Given this list of marker genes Ret, Sgk1, Nucb2, Got1, Grk2, Bcar1, Irs4, Ptpra, Trib3, Ntrk2, Rps6kb2, Irs2, Snx5, Mir494, Gsk3b, Prkcq, Flt3, Ephb3, Ephb1, Pdgfrb, Mtor, Cdk2, Pid1, Pck1, Mtcl2, Socs3, Pik3r1, Mst1r, Erbb4 (erb-b2 receptor tyrosine kinase 4), Rbx1, Mzb1, Marcks, Agt, Eef2k, Sos2, Eif4ebp1, Gpr21, Sirt1, Ywhag, Sgcb, Tek (NCBI Gene Id 99999), Gpld1, Prkca, Hdac9, Mapk1, Gck (glucokinase), Ptpn1, Ncoa2, Il1b, Obp2a, Rps6kb1, Igf1r, Usf1, Gclc, Ffar3, Slc27a4, Socs7, Prkci, Map2k1, Rb1, Ankrd26, Fut7, Blvrb, Slc2a8, Cul7, Ins1, Ucp2, Pik3ca, Grb7, Hmga1, Stxbp4, Ptpre, Ghsr, Ddr1, Fbp1, Vamp2, Lpin2, Cpeb2, Kbtbd2, Rab8a, Kank1, Gpt, Pten, Ptpn2, Epha8, Cul3, Pdk4, Lep, Pkm, Cav2, Epha2, Ptpn11, Mup2, Ptprv, Foxo1, Sh2b2, C2cd5, Mir143, Flt1, Foxc2, Ptprf, Sorl1, Esrra, Slc2a4, Lpl, Igfbp1, Prkcd, Ptprj, Nucks1, Serpina12, Cpeb1, Appl2, Eprs1, Smarcc1, Axl, Inppl1, Pdpk1, Csf1r (NCBI Gene Id 12978), Srebf1, Sik2, Star, Slc25a33, Pip4k2a, Ncl, Bcar3, Epha5, Xbp1, Zfp36l1, Mfn2, Fgfr2, Blvra, Ndel1, Ide (NCBI Gene Id 73765), Inpp5k, Otop1, Grb14, Pck2, Slc27a1, Slc9a1 (NCBI Gene Id 20544), Ccl2, Lonp1, Epha6 (Eph receptor A6), Ncoa5, Igf2, Atp2b1, Mapk3, Mup1, Epha10, Rab10, Gh, Cyfip1, Uso1, Vwa2, Zfp592, Foxo4, Pdgfra, Ceacam1, Ctsd (cathepsin D), Opa1, Capn10, Uchl3, Grb2, Epha1, Sco1, Dnai1, Osbpl8, Fgfr3, Erfe, Mapkap1, Gstp1, Akt3, Myo1c, Dennd4c, Irs3, Lpin3, Met, Pou4f2, Pik3r2, Egfr, Hras, Mup4, Tsc2, Ceacam2, Pdk2, Tns2, Zbtb7b, Enpp1, Rhoq (NCBI Gene Id 80836), Slc39a14, Epha7, Ntrk3, Zdhhc7, Nr1h4, Rab31, Gpam (NCBI Gene Id 14732), Kat2b, Fbxw8, Rarres2, Pak1, Musk, Tyro3, Ntrk1, Kdr, Ephb2, Ggcx, Fgfr4, Ahsg, Gsk3a, Tnf, Flt4, Tie1, Ncoa1, Ros1, Zfp106, Irs1, Pde3b, Insr, Hnrnpk, Eif4ebp2, Rab13, Insrr, Lpin1, Akt2, Pcsk9, Insig1, Pparg, Mup5, Prkcz, Csrp3, Mup3, Plcb1, Trim72, Erbb2, Rbm4, Sp1, Inhbb, Srsf3, Gnai2, Parp1, Mertk, Sesn3, Ddr2, Ephb4, Ltk, Mstn, Insig2, Gkap1, Src, Col6a1, Ror2, Adipor1, Prkdc, Hmgcs2, C1qtnf9, Nck1, Adipoq, Alk, Apc, Ghrhr, Pik3r3, H2az1, Pax6, Epha4, C1qtnf12, Epha3, Sorbs1, Prkaa1, Akt1, Bglap, Grb10, Shc1, Bglap3, Kit, Sos1, Tbc1d4, Bglap2, Ins2, Fer, Trarg1 (trafficking regulator of GLUT4 (SLC2A4) 1), Syap1, Pip4k2b, Mup11, Wdtc1, Appl1, Socs1, Rela, Ogt, Myo5a (NCBI Gene Id 57374), Prkcb, Raf1, Phip, Pip4k2c, Fgfr1, Echdc3, Pklr, here is a description of the gene set: Any process that results in a change in state or activity of a cell (in terms of movement, secretion, enzyme production, gene expression, etc.) as a result of an insulin stimulus. Insulin is a polypeptide hormone produced by the islets of Langerhans of the pancreas in mammals, and by the homologous organs of other organisms. Mouse Gene Set: GOBP_CELLULAR_RESPONSE_TO_INSULIN_STIMULUS species: Mus musculus